Given this list of marker genes Jund, Kpna2, Commd7, Smg5, Zscan21, Bub1, Aurka, Ifnar2, Nek2, Trafd1, Orc5, Uck1, Hmgn1, Anln, Cdc25c, Prc1, Pttg1, Cul1, Tcf19, H2ax, AI506816, Cks2, Cdc20, Syncrip, Mapre1 (NCBI Gene Id 99354), Kif22, Ect2, Ncdn, Timp2, Mthfd2, H2-K1, H2ac4, Cdt1, Tnnc1, Fam76b, Alas1, Plk-ps1, Itgb7 (integrin beta 7), H3c13, here is a description of the gene set: Mouse Gene Set: HU_GENOTOXIC_DAMAGE_4HR Genes most consistently regulated at 4 h by all six genotoxins tested: cisplatin, methyl methanesulfonate, mitomycin C, taxol, hydroxyurea and etoposide. from publication Hu T, Gibson DP, Carr GJ, Torontali SM, Tiesman JP, Chaney JG, Aardema MJ (PMID 15120960) During the safety evaluation process of new drugs and chemicals, a battery of genotoxicity tests is conducted starting with in vitro genotoxicity assays. Obtaining positive results in in vitro genotoxicity tests is not uncommon. Follow-up studies to determine the biological relevance of positive genotoxicity results are costly, time consuming, and utilize animals. More efficient methods, especially for identifying a putative mode of action like an indirect mechanism of genotoxicity (where DNA molecules are not the initial primary targets), would greatly improve the risk assessment for genotoxins. To this end, we are participating in an International Life Sciences Institute (ILSI) project involving studies of gene expression changes caused by model genotoxins. The purpose of the work is to evaluate gene expression tools in general, and specifically for discriminating genotoxins that are direct-acting from indirect-acting. Our lab has evaluated gene expression changes as well as micronuclei (MN) in L5178Y TK(+/-) mouse lymphoma cells treated with six compounds. Direct-acting genotoxins (where DNA is the initial primary target) that were evaluated included the DNA crosslinking agents, mitomycin C (MMC) and cisplatin (CIS), and an alkylating agent, methyl methanesulfonate (MMS). Indirect-acting genotoxins included hydroxyurea (HU), a ribonucleotide reductase inhibitor, taxol (TXL), a microtubule inhibitor, and etoposide (ETOP), a DNA topoisomerase II inhibitor. Microarray gene expression analysis was conducted using Affymetrix mouse oligonucleotide arrays on RNA samples derived from cells which were harvested immediately after the 4 h chemical treatment, and 20 h after the 4 h chemical treatment. The evaluation of these experimental results yields evidence of differentially regulated genes at both 4 and 24 h time points that appear to have discriminating power for direct versus indirect genotoxins, and therefore may serve as a fingerprint for classifying chemicals when their mechanism of action is unknown. species: Mus musculus